Given this list of marker genes Sptbn1, Dnd1, Sf1, Inha, Ndrg2, Nr0b1, Cdkn2c, Ar, Fzr1, Ctnnb1, Trp53, Men1, here is a description of the gene set: Mouse genes annotated to increased testis tumor incidence (MP:0006262) retrieved from the Mouse Genome Informatics database via MouseMine Mouse Gene Set: MP_INCREASED_TESTIS_TUMOR_INCIDENCE from publication Motenko H, Neuhauser SB, O'Keefe M, Richardson JE (PMID 26092688) studied in species Mus musculus